Given this list of marker genes TUBB3, IL1RL1, PDE5A (NCBI Gene Id 8654), ASH2L, LRPAP1, MDH1, NDUFB3, ATP6V0B, MFAP1, MAPRE1, ADSL, CA9, PRKCA, ZNHIT3, SMARCA1, ATP6V0D1, MDM2, EXOC2, FAIM, LHFPL2, S100A10, EIF5, AKT1S1, VBP1, PCID2, NDUFAB1, FHL1, MAL, METTL13, KIFBP, AKR7A2, CD63 (CD63 molecule), STK24, SPA17, PFKM, GNG12, MRPS22, TUBA3C, TMEM248, NDUFB11, RPL10A, IGFBP1, DUSP12, H4C2, CYC1, VDAC1, BTF3 (NCBI Gene Id 689), GOLT1B, BZW1, RAB1A, CAV1, CDH2, DCAF13, LAPTM4A, TMCO1, CX3CR1, TMBIM4, TMEM258, RNASE4 (ribonuclease A family member 4), SMIM12, SPCS1, SLC25A33, IFRD1, PPP2CB, GRB2, RAN, VKORC1, KIF11, ACADM, MAP4K3, CBFB, APLP2, SELENOP, TCEAL9 (transcription elongation factor A like 9), MRPL15, NCOA4, MMADHC, ATRAID, SPARC, MRPL37, PLAAT3 (phospholipase A and acyltransferase 3), ALDH1A2, TUBA4A, IFITM2, EPB41L3, CLIC4, COX8A, PRDX5, ANLN, DCK, TMEM199, EMP1, MYB, SCD, CHCHD2, AK4, SRI, PMP22, IDE, CXCL12, MAGEA6, SDCBP, VCAN, DHRS11, SHB, PAICS, ATL3, KLF10, ENO1, NME2 (NME/NM23 nucleoside diphosphate kinase 2), SET, HSPA8, GHITM, TP53I3, ANO6, MMP2, SMDT1, EDNRB, L1CAM, CTSB, DSG2, GGH, ITGAV, ENC1, YWHAQ, COX6B1, CHCHD1, HIBADH, CCT5, H3C4 (NCBI Gene Id 8351), TMEM50B, SLC25A17, SLC38A9, TMEM9B, ELOC, BRK1, ATP5MGL, EIF1B, PPP1R8, FGG, TGFBR2, ACSL3, SLC30A6, PTPRZ1, RBM4, FAM114A1, GABARAP, LUM, RABAC1, PRKAR1A, LIPA, GSTA4, XRCC5, H4C3 (NCBI Gene Id 8364), CDYL, UBE2D2, GLO1, ARID5B, LAMTOR5, GTF2H2, BCCIP, FZD1, DAD1, RCBTB2, WEE1, NPC2, PFN1, EIF3H, PPP1R3C, UBL5, APEX1 (NCBI Gene Id 328), GON7, NHP2, TUBA1A, ADK, PPP2R5C, SKP1, HMMR, CDKN1A, SDHD, CASP5, RRAGA, RPS10, CKS1B, TIMM10, TXNRD1, CDC5L, SERPINA3, RPL35A, CGA, MMGT1, SERINC1, PMM1, POLR3K, here is a description of the gene set: Metastatic disease is the primary cause of death in cutaneous malignant melanoma (CMM) patients. To understand the mechanisms of CMM metastasis and identify potential predictive markers, we analyzed gene-expression profiles of 34 vertical growth phase melanoma cases using cDNA microarrays. All patients had a minimum follow-up of 36 months. Twenty-one cases developed nodal metastatic disease and 13 did not. Comparison of gene expression profiling of metastatic and nonmetastatic melanoma cases identified genes with a >2-fold differential expression ratio and a false discovery rate of <0.2 (206 up-regulated and 37 down-regulated). This set of genes included molecules involved in cell cycle and apoptosis regulation, epithelial-mesenchymal transition (EMT), signal transduction, nucleic acid binding and transcription, protein synthesis and degradation, metabolism, and a specific group of melanoma- and neural-related proteins. Validation of these expression data in an independent series of melanomas using tissue microarrays confirmed that the expression of a set of proteins included in the EMT group (N-cadherin, osteopontin, and SPARC/osteonectin) were significantly associated with metastasis development. Our results suggest that EMT-related genes contribute to the promotion of the metastatic phenotype in primary CMM by supporting specific adhesive, invasive, and migratory properties. These data give a better understanding of the biology of this aggressive tumor and may provide new prognostic and patient stratification markers in addition to potential therapeutic targets. from publication Alonso SR, Tracey L, Ortiz P, Pérez-Gómez B, Palacios J, Pollán M, Linares J, Serrano S, Sáez-Castillo AI, Sánchez L, Pajares R, Sánchez-Aguilera A, Artiga MJ, Piris MA, Rodríguez-Peralto JL (PMID 17409456) Human Gene Set: ALONSO_METASTASIS_UP species: Homo sapiens Up-regulated genes in melanoma tumous that developed metastatic disease compared to primary melanoma that did not.